The following is a description of a gene set: studied in species Homo sapiens Immotile sperm Human Gene Set: HP_IMMOTILE_SPERM A lack of mobility of ejaculated sperm., and this is the list of marker genes: CFAP65, CCDC39, CDC14A, CFAP70, STRC, DZIP1, DNAJB13 (NCBI Gene Id 374407), CCDC40, IFT74, CATSPER1, SPINK2, CATSPER2, DNAAF5, GAS2L2, RSPH9